Given this list of marker genes ATP6V1F, ATP5PO, ANXA1 (annexin A1), ATP5F1A, ATP5MC1, ANXA3, ATP5MC3, ATP6V1E1, PEBP1, CAVIN2, ATP5MC2, ATP5F1E, PLSCR1, CDIPT, ANXA5, ATP5F1B (NCBI Gene Id 506), ATP5F1D, here is a description of the gene set: Genes in the cancer module 414. Human Gene Set: MODULE_414 species: Homo sapiens